The following is a description of a gene set: Any process that stops, prevents, or reduces the frequency, rate or extent of protein localization to chromatin. studied in species Homo sapiens Human Gene Set: GOBP_NEGATIVE_REGULATION_OF_PROTEIN_LOCALIZATION_TO_CHROMATIN, and this is the list of marker genes: CDK9, VCP, SPI1, RNF4, PIAS4, LNCPRESS1, SIRT6